The following is a description of a gene set: Although several markers have been associated with the characterization of regulatory T cells (Treg) and their function, no studies have investigated the dynamics of their phenotype during infection. Since the necessity of Treg to control immunopathology has been demonstrated, we used the chronic helminth infection model S. mansoni to address the impact on the Treg gene repertoire. Before gene expression profiling we first chose to study the localization and antigen-specific suppressive nature of classically defined Treg during infection. Presence of Foxp3+ cells were found especially in the periphery of granulomas and isolated CD4+CD25hiFoxp3+ Treg from infected mice blocked IFN-gamma and IL-10 cytokine secretion from infected CD4+CD25- effector T cells (Teff). Furthermore the gene expression patterns of Treg and Teff showed that in total genes were significantly regulated during chronic schistosomiasis. Upon k-means clustering we identified genes exclusively regulated in all four populations including Foxp3, CD103, GITR, OX40 and CTLA-4: classical Treg markers. During infection however, several non-classical genes were up-regulated solely within the Treg population such as Slpi, Gzmb, Mt1, Fabp5, Nfil3, Socs2, Gpr177 and Klrg1. Using RT-PCR we confirmed aspects of the microarray data and in addition showed that the expression profile of Treg from S. mansoni-infected mice is simultaneously unique and comparative with Treg derived from other infections from publication Layland LE, Mages J, Loddenkemper C, Hoerauf A, Wagner H, Lang R, da Costa CU (PMID 20007528) studied in species Homo sapiens Human Gene Set: GSE17580_UNINFECTED_VS_S_MANSONI_INF_TREG_DN Genes down-regulated in comparison of regulatory T cell (Treg) from uninfected mice versus regulatory T cell (Treg) from mice infected with S. mansoni., and this is the list of marker genes: STT3A, POLR2C, FABP5, LITAF, SEPHS2 (NCBI Gene Id 339090), PSME2, CXCR3, MYO6, NEFH, METRNL, LRPAP1, CEMIP2, COX16, CNIH4, STK39, MZT2B, CDKN2C, SLC30A2, CASP4, POMP, CPQ, PROS1, PTDSS2, SLC39A6, PMEPA1, THOC7, RAI14, CCR5, FGL2, BID, SRP14, DAPK2 (NCBI Gene Id 23604), DENR, TPD52L1, GZMB, GPM6B, KYAT3, DBI, ATP6V1A, LPIN2, PRG2, GM2A, POLR2K, RPA3, UAP1, UNG, CELA1, S100A10, BUD31, MRPL57, GLRX, RBM3, NUDT1, ATP5PB, CYB5R4, MRPL14, S100A11, CACNA1C, ZCCHC17, METAP2, PLAAT3, SCCPDH, ZFP91, PDE1C, AREG, TXNRD1, PPM1G, GIMAP7, POLR3H, SLC22A4, TGM2, FUCA2, DNAJC15, FARSB, NDUFS6, PAFAH1B3, TMEM126A, KLRG1, TMA7, RAD21, LGALSL, ALAD, F2R, HTATIP2, LRRK1, ORMDL2, PMM1, COX7A2, TIMM13, STARD10, LRRC59, ALDOC, UHRF1, NENF, TG, RASGRF1, SEC11C, PHGDH, CASP3, TMT1A, NKG7, AKR1B15, IL10 (NCBI Gene Id 3586), PIK3CG, STX8, MINPP1, NUP155, PRDX2, USP25, UBD (ubiquitin D), LZTFL1, ID2, COX8A (NCBI Gene Id 1351), SHC3, SNHG8, PCK2, B3GNT9, LGALS1, CTTN, RRBP1, UQCR10, NUCKS1, MYO1D, TRAPPC1, RAB20, BCL7C, CYB561, TRIM37, S100A6 (S100 calcium binding protein A6), BCL2L15, TM2D1, IFNG, TBX21, LAMP2, SMARCD2, IL21, IL4, UFC1, SMPDL3B, ATP5MK, BHLHE40, EPRS1, CXCL3, EGLN3, HINT3, ENPP1, TMEM14C, NME1, DNMT1, PENK, HYCC1, RBX1, ATP5MC1, ATP5MG, BCL2A1 (NCBI Gene Id 597), CIAO2A, MRNIP, IMPA2, EIF4EBP1, MRPS34, NEDD8, FECH, NTMT1, SLC66A3, ATP5ME (NCBI Gene Id 521), FAIM, RYK, RUNX2, DAP, ACSL5, NDUFS4 (NCBI Gene Id 4724), VDR, DNPEP, PAXIP1, NAB1, SELENOM, EMC9, NIBAN2, PRELID3B, IAPP (NCBI Gene Id 3375), TMEM223 (transmembrane protein 223), ANTXR2, MRPL20 (mitochondrial ribosomal protein L20), WEE1, FURIN, IGHG1, POLE3 (DNA polymerase epsilon 3, accessory subunit), ATP13A3, GRB7, CEP85, SARNP, RPS27L, BATF, CNPY2, INSL6, PGP, TRPC1, ST6GALNAC4, TIMM8B, FANCF